The following is a description of a gene set: The multiplication or reproduction of vascular smooth muscle cells, resulting in the expansion of a cell population. A vascular smooth muscle cell is a non-striated, elongated, spindle-shaped cell found lining the blood vessels. studied in species Homo sapiens Human Gene Set: GOBP_VASCULAR_ASSOCIATED_SMOOTH_MUSCLE_CELL_PROLIFERATION, and this is the list of marker genes: MIR27A, SOD2, MIR96, DNMT1, RGS5, MIR17, MIR665, GNAI2, MIR499A, P2RY6, POLDIP2, HTR1B, ADAMTS1, HPGD, MIR133A1, NF1, MIR222, MIR135B, IGFBP5, MIR26A1, MIR1-1, MIR4632, MMP2, MIR301A, MAP3K7, PTEN (phosphatase and tensin homolog), MIR362, XBP1, TGFB3, TPM1, CDKN1B, ERN1, RBM10, DDR2, MIR130A, JAK2, CALCRL, PDCD4, PRKG1, MIR34A, MIR21, GNA12, BMP4, MDM2, TNF, GSTP1, PAK1, TAFA5, APLN, GPER1, MIR424, MIR27B (NCBI Gene Id 407019), FOXJ2, GJA1, MAP3K5, EDN1, IGF1, MIR15A, BMPR1A, MIR182, FGFR2, MIR339, CDKN1A (NCBI Gene Id 1026), MIR208A, MIR448, MIR221, MYOCD, NR4A3, MMP9, CNN1, MIR185, MEF2C, DBH, RGCC, DDIT3, NDRG2, MIR503, EFEMP2, LDLRAP1, MIR638, TERT, MIR137, MIR146A, IL10 (interleukin 10), FGF2, MFN2 (mitofusin 2), MEF2D, PPARG, MIR20A, MIR214, PDGFB, MIR1298, ADIPOQ, MIR140, JUN, FGF9, MIR223